Given this list of marker genes CSDE1, NEAT1, SND1, XPO5, DHX9, here is a description of the gene set: studied in species Homo sapiens Binding to a RISC complex. Human Gene Set: GOMF_RISC_COMPLEX_BINDING